Given this list of marker genes Tfdp1, Smad7, Ccnc, Mapk3, Ccnk, Ccnt2, Rps27a, Smad4, Mapk1, Wwtr1, Smad3, Ccnt1, Uba52, Uba52rt, Rnf111, Sp1, E2f5, Cdk8, Rbl1, Furin, Cdk9, Smad2, Ubb, E2f4, Ubc, Men1, here is a description of the gene set: studied in species Mus musculus SMAD2/SMAD3:SMAD4 heterotrimer regulates transcription Mouse Gene Set: REACTOME_SMAD2_SMAD3_SMAD4_HETEROTRIMER_REGULATES_TRANSCRIPTION